Given this list of marker genes YY1AP1, SMARCA5, ING3, DPF3, DPF1, DMAP1, SMARCA2, SMARCB1, RBBP7, RB1, INO80, MYO1C, EP400, GATAD2B, DEK (NCBI Gene Id 7913), MTA1, BAZ2A, POLE3, MCRS1, BRD9, SRCAP, SMARCC2, ARID1A, RBBP4, YY1, ACTB, ERCC6, RUVBL2, CHD4, MTA3, BCL7C (NCBI Gene Id 9274), BAZ1B, BCL11B, INO80C, BRD7, DPF2, BCL11A, ZNHIT1, C17orf49, BCL7B, NFRKB, MTA2, ACTL6B, SMARCE1, SMARCD3, BICRA, SMARCC1, TRRAP, KAT5, CDK2AP2, GATAD2A, SMARCA4, ARID1B, HMGXB4, PHF10, CECR2, SF3B1, BICRAL, HDAC2, SMARCA1, ACTR8, CDK2AP1, ARID2, BCL7A, LUZP1, HDAC1, SUZ12, CHRAC1, MBD2, BAZ1A, DDX21, ACTR5, SS18, INO80E, CFDP1, UCHL5, INO80B, ACTR6, RUVBL1, MBD3, INO80D, BRD8, CHD3, SMARCD1, NCR1, SS18L1, ANP32E, RSF1, BPTF, TFPT, MYBBP1A, CHD5, PBRM1, SMARCD2, ACTL6A, here is a description of the gene set: species: Homo sapiens Human Gene Set: GOCC_SWI_SNF_SUPERFAMILY_TYPE_COMPLEX A protein complex that contains an ortholog of the Saccharomyces ATPase Swi2/Snf2 as one of the catalytic subunit components (ATPase) and mediates assembly of nucleosomes, changes to the spacing or structure of nucleosomes, or some combination of those activities in a manner that requires ATP.